Given this list of marker genes PSEN1, THSD7A, INPP5A, FOXO4 (NCBI Gene Id 4303), ZNF652 (NCBI Gene Id 22834), ACTBL2, STON1, MAEL, C2orf66, HTR2C, ALS2, BIRC3, NT5C2, CNTN5, RANBP9, EMC2, ETV1, MED20, GABRA3, EPDR1, BOD1, BRWD1, TMF1, CLEC2A (NCBI Gene Id 387836), NCR3LG1, MRPL30, LMCD1, ZNF711, MSX2, LDB2, HNRNPLL, RARG, F11, ITGAV, NDUFS4, DCUN1D4, PFKM, ZNF736, PACS2, SH3TC2, ZNF91, PHYHIPL, ST6GALNAC1, FBXO7, NIPA2, FBXL17, BRWD3, RSRC2, LINC03106, MYBL1 (NCBI Gene Id 649850), GRID2, HECTD1 (HECT domain E3 ubiquitin protein ligase 1), RNF14, MEF2C, TRIM33, RSF1, HMGCR, OGN, TOP2B, FAM110C, PBX1, INPP5F, ERG, PDE4B, MED13L, TOB1, DMTF1, FLT3, TSPAN12, NALCN, CCDC73, DONSON, here is a description of the gene set: Genes predicted to be targets of miRBase v22 microRNA hsa-miR-20b-3p in miRDB v6.0 with MirTarget v4 prediction scores > 80 (high confidence targets). Human Gene Set: MIR20B_3P species: Homo sapiens from publication Chen Y, Wang X (PMID 31504780)